The following is a description of a gene set: Genes containing one or more binding sites for (Pcgf5) in their promoter regions (TSS -1000,+100 bp) as identified by GTRD version 20.06 ChIP-seq harmonization. species: Mus musculus from publication Yevshin I, Sharipov R, Kolmykov S, Kondrakhin Y, Kolpakov F (PMID 30445619) Mouse Gene Set: PCGF5_TARGET_GENES, and this is the list of marker genes: Ctbp2, Gm12354, Gm5316, Brd2, Gm16111, Mccc1, H2-D1, Hsp90ab1, Trp53i11, Mir322, Pla2r1, Srsf9, Aprt, Celsr1, Usp11, Elovl5, Aldh6a1, Odf2, Prmt5 (NCBI Gene Id 27374), Tdrd7, Sumf2, Mrpl17, Pip4p2, Rassf1, Icmt, Rab33b, Cox6b2, 1600020E01Rik, Afg3l2, Arid5a, Tcf7l1, Rtkn, Nfe2l1, Ogfod2, Mast2, Ptprj, Etv6, E130307A14Rik, Rtn4, Ccdc106, H2bc11, Amdhd2 (amidohydrolase domain containing 2), Jhy, Tmem74b, Krt19, Mir503, Gm24459, Ndufb10, Spag7, Ddx42, Rbms1, Cox7a1, 1700045H11Rik, Gm15697, Tbc1d24, Grb10, Dleu2, Slf1, Ybx3, Apc, Fat1, Gm7988, Rnf44, Eif2b4, Mir292, Mov10l1, Mir290b, Mrpl12, Pdia3, Rgs10, Ptprcap, Cyb5rl, Psmb4, Atg7, Gm24763, Abt1, Pcif1, Fbxl14, Hook1, Mapre3, C230035I16Rik, mt-Ta, Nip7, Tmed1, Rfc4, Cep131, Strbp, Ap1g2, Smpd3, mt-Tn (mitochondrially encoded tRNA asparagine), Hnrnph1 (NCBI Gene Id 59013), Chtf18, Dip2c, Ubn2, Agbl5, Xrcc2, Hotairm1, Ints11, Top1, Cpsf1, Fhdc1 (FH2 domain containing 1), Phyhipl, Yipf1, Gm24313, Calu, Gm14135, Ankrd39, Rasa1, Ccna2 (cyclin A2), Fcsk (NCBI Gene Id 68821), 2610005L07Rik, Fastk, Akna, Ppp4c, Hmg20b, 2510017J16Rik (RIKEN cDNA 2510017J16 gene), Exo1, Mdm1 (NCBI Gene Id 492875), Plekha5, H2ac7, Tk1, Pigz, Arhgap29, Tcea3, Lrig1, Ptger4, Ndufa10, Yrdc, Fam8a1, Mier3, Gm4189, Suv39h2, Dcaf12, Pex19, mt-Co2, Scamp3, Vgll3, 3000002C10Rik, Traj49, Tk2, Mir3073b, Snhg17 (NCBI Gene Id 68108), Nabp1, Pprc1, Klrh1, Pfdn6, Nfx1, Rpl37a, Gm9530, Nars1, Slc25a11, Trim11, Cbarp, Snord37, Git2, Usp20, Psmd14, Ttbk1, Samd1, Gm25784, H4c9, Niban3, Esrp2, Gdi2, Gm15564, Cenpx, Phldb1, Gm12153, Dnai7, Ptges3, Arl4c, Disp1, Gm11771, Pabpn1, Cryz, Mrps14, Mir3075, Csde1, Ccdc47, Dusp18, Tnnt2, Srd5a3, Flacc1, Hs2st1, Pik3cb, Nop2, Tenm3, Gm40055, Cspp1, Tra2b, Miip, Trim14, Jcad, Ino80, Foxj3, Nfrkb, Rchy1, Lman1, Rsf1, Cald1, Tnpo2, Cfap53, Ubtf, Vps13d, Hipk1, Eef2k, Gstm1, Psmd3, Ttn, Safb2, Gm11270, Arhgap8, Grin2c, Fbxl3, Prr3, Dcaf8, Sfi1, Dock7, Sdhd, Grid2ip, Cep95, Gm9837, Vps25, Gm26579 (predicted gene, 26579), Cemip2, Gna11, Dvl2, Atp5po, Cul7, Gps2, Pcdhga2, E2f7, Gal3st4, Atf7ip, Psmc3, Gm4753 (predicted gene 4753), Lrrc59, Mcm7, Lmo7, Gm5069, Rnu12, Ccdc62, Zpbp2, Bag6, Hnrnpu, Hnrnpa1, Ncoa3, Cep170, Csnk1a1, Gm11743, Dis3l, Itgb3, Ube2d-ps, Hyal2, Ssbp2, Fbxl12, Pcbp1 (poly(rC) binding protein 1), Mir5123, 4930404I05Rik, Wdr75, Ncald, Hnrnpd, Gm12542 (predicted gene 12542), Polr3k, Tango2, Cct6a, Fis1, Svil, Lrrc45, Msl3, C130046K22Rik, Skp2, Nme6, Npm3, Pcyt1a, Sec24b, Thrap3, Myo1c, Snora62, Mir7-1, 4930577N17Rik, Nectin3, Prkab2, Krtcap2, Rgl2, Slc35a4, Impdh2, Ift46, Frg2f1, Cd2bp2, Kbtbd7, Nat10, 3110045C21Rik, Gm9939, 1110008E08Rik, Tpm4, Snx17, Traf1, Gm24381, Or9s23 (NCBI Gene Id 259039), Dnajc21, Srsf1, Ipo4, Tcirg1, Epb41, Cbx5, Rnf151, Dhrs13, Ppm1g, Ccn4, Prdx5, Szrd1, Ccser2 (coiled-coil serine rich 2), Bnip3l, Rbm17, Zmynd15, Gm6238, Ext1, Ercc2, Vamp8, Alyref, Synj1, Or1ad5-ps1, Dlec1 (deleted in lung and esophageal cancer 1), Cct8, Hps5, Git1, Prune2, Gm10636, Poldip3 (polymerase (DNA-directed), delta interacting protein 3, NCBI Gene Id 97955), Chmp2a (charged multivesicular body protein 2A), Fuca1, Gm22381, Myh10, Ubl5 (ubiquitin-like 5), Cdc42bpa, Krtap19-4, Mir6236, Rad18, Rcor3, Coro6, Gpn2, Cox19, Clcn2, Abca3, Asph, Ring1, Fnbp4, Fv1, Anapc11, Dapk3, Stag1, Lnpep, Srrm2, Kifc1, Lmbrd2, Ctnnbip1, Sft2d1, Hp1bp3, Ets2, Slc24a3, Pgam1, Myo1b, Slc6a8, Kctd13, Zfp318, E130317F20Rik, Sap25, Mir6386, Ahctf1, Tfap2c, Tle3, Hdgf, Kctd20, H2ac10, Dpp7, 4921536K21Rik, Sqle (squalene epoxidase), Mir8096, Sac3d1, Saxo5 (stabilizer of axonemal microtubules 5, NCBI Gene Id 76406), Hmga1, Epb41l1, Golph3, Cct5, Gm14168, 4930579G18Rik, H3f3b, Arcn1, B4galt5, Cxcl16, Hsd17b4, Rubcn, Lta4h, Ppp1r15b, Gm6522, Arpc5l, Plet1os, 2610203C22Rik, Eif4a1, Nebl, Afdn, Eef1a1, Hhip, Ddx59, Slc2a8, Slc4a1ap, Rassf7, Mphosph9, Ctr9, Sumo2, Plekha6, Irag2, Gm26560, Ptpn9, Gm11973, Mapkbp1 (mitogen-activated protein kinase binding protein 1), Cyp4f16, Gm11292, Vps50, Ptbp1, Gm5627, Tcta, Tchp, Epo, Ctsd, H2bc7, Junos, 1700064H15Rik, Adrm1, Wdr46, Arl6ip4, Mir1983, Anxa2, Mir291a, Fyttd1, Ddx5, Limk2, Ube3a, Crtc2, Vps53, Prkci, Csnk1e, Sfxn2, mt-Td, Ldha, Kifc5b, Tyw3, Apoc2 (NCBI Gene Id 11813), Akr1cl, Wrap73, A730020M07Rik, Kctd12, Sh3bp2, Crebzf (NCBI Gene Id 70721), Maz, Macroh2a1, Nol7, Tob1, Hexim2, Gabarap, Slc35c2, Enoph1, Gm23262, Etfrf1, Gm5276, Mettl26, Vwf, Mtif2, Psmb3, Amotl1, Tatdn2, Bap1 (NCBI Gene Id 69465), Zfp605, Mir7016, Acaa2, Xpo6, Afmid (NCBI Gene Id 71562), Efcab5, P4ha1, Usp34, Klhdc10, Rhog, Ppid, Arfgap2, Xkr6, Igf2, Dqx1 (DEAQ RNA-dependent ATPase), Fblim1, Yif1a, Spmap1, 2610037D02Rik (NCBI Gene Id 75768), Rab11a, Zbtb46, Zfp36l2, Scly, Sf3b1, Zbtb11, Mir1188, Hectd2, Polr1b, Plekhg2, Ptprjos1, Adap1, Mst1r, Gosr2, Chct1, Pnpla2 (NCBI Gene Id 68551), Myl12a, Pcmt1, Cenpl, Dhps, Paf1, Vti1b, Cldn11, Mkln1, Mia2, Mta2, Kpna1, Ext2, Cand1, Inpp5k, Nqo1, Dapk2, Scp2, Acin1, Gm23119, Gm14383, Gpr15lg, Dvl1, Slc36a1, Mir341, Cfap418, Edem1, Smug1, Gm24032, Plekhh1, Snx21, Scarna17, Cdc42se1, Abca4, Gnb2, Arhgef2, Lats1, Gm26779, Pip5k1a, Fam131a, Usp21, Gm11205, Dnm1, Mir219c, D930028M14Rik, mt-Ty, Egfl7, Tbce, 1810044D09Rik, A430102K17Rik, Bcl2, Septin11, Ap2a2, Eif4g2 (NCBI Gene Id 77989), Rwdd4a, Anapc10, Rps2, Chd3, Dab2ip, Isyna1, Iws1, Igf2os, Mucl3, Wdfy3, BC005624, Josd1, Sacm1l, Gpt2, Mir291b (microRNA 291b), Mkln1os, Btg1, Knl1, Cad, Cpeb3, Metrnl, Susd6, Ncmap, Mynn, Ubl3, Zc3h4, Inpp1, Ddx55 (NCBI Gene Id 67848), Ctnna3, Mpc1, Gm29707, Cd68, Gpatch2l (G patch domain containing 2 like), Cog4, Tomm40l, Map3k2, Myog, Trmt10a, Gm34106, Snrnp40, Mir503hg, Myl6b, Snx14, Gm9917, Gm2415, Clasrp, Dync1h1, Elmod2, Sun1, Eif4a3, Safb, Nek2, Gtf2ird2, Lasp1, Mir3471-1, mt-Tc, Mrtfa, Slc37a1, Rhoa, Ccdc38 (NCBI Gene Id 237465), Prkag1, Nme7, Ddx46, Mdc1, Mir7666, Ino80b, Drg2, Or14a260, Rsad1, Hnrnpdl, Gm16519, Selenof, Gm16510, Cmip, Mapk8ip3, Clasp1, Mob3c, Gmpr, Rnf167, Lgals9, Ddit3, Grn, Ctdspl, Gps1, Fth1, Orc2, Pgm1